Given this list of marker genes MTOR, METTL3, NCK1, PKP1, IMPACT, RPL13A, HHEX, SH3BGRL, YTHDF2, AKT2, here is a description of the gene set: species: Homo sapiens Any process that modulates the frequency, rate or extent of cytoplasmic translational initiation. Human Gene Set: GOBP_REGULATION_OF_CYTOPLASMIC_TRANSLATIONAL_INITIATION